The following is a description of a gene set: species: Homo sapiens Defects of platelet adhesion to exposed collagen Human Gene Set: REACTOME_DEFECTS_OF_PLATELET_ADHESION_TO_EXPOSED_COLLAGEN, and this is the list of marker genes: COL1A2, GP9, GP1BA, GP5, VWF, ADAMTS13, COL1A1, GP1BB